The following is a description of a gene set: studied in species Mus musculus Mouse Gene Set: GOBP_MEMBRANE_LIPID_METABOLIC_PROCESS The chemical reactions and pathways involving membrane lipids, any lipid found in or associated with a biological membrane., and this is the list of marker genes: Sftpb, Smpdl3a, Sptlc2 (serine palmitoyltransferase, long chain base subunit 2), Glb1, Neu1, Fut4, Pigo, Lct, Naglu, Th, Elovl5, Pigyl, Serinc1, Elovl1, Pigg, St6galnac3, Htra2, Cers2, Ormdl1, Hacd2, Hacd4, Gla, Gal3st3, Crem, Prkcd, Pigw, St6galnac6, St6galnac5, Vapa, Acer2, Gal3st2, St6galnac1, Pigb, Asah2, B4galt5, Casp7, Pign, Fads3, Pigv, Hacd3, Pigf, Ugt8a, Smpd2, Pigc, St8sia2, Tlcd3b, Sgms2, Dpm3, Degs1, Smpdl3b, Pigt, Gbgt1, St3gal4, Pgap2, Tecr, Eed, Mecr, St6galnac4, Sptssa, Hexa, Sphk1, Gsdmd, Sirt3, Fut2, Pgap3, Dpm2, Arv1, Enpp2, Cers4, Sptlc1 (NCBI Gene Id 97860), Smpd1, Acer3, St8sia4, Fa2h, Ormdl3, Smpd3, Pemt, Etnppl, Zfp750, Smpd5, Pigp, B3galt1, Gal3st1, Cln6, Pgap4, Enpp7, St8sia3, Psap, Sgpp1, Cwh43, Galc, Cln8, St8sia1, Naga, Ccn1, Prf1, Vps54, Kdsr, Abca2, Sptlc3, Elovl4, B4galt4, Pyurf, Pigm, St3gal3, Osbp, Degs1l, Paqr4, Pigu, Cerkl, P2rx7, Cyp1b1, B3galt2, Psapl1, Casp1, Sccpdh, 6430550D23Rik, Agmo, Abca8b, Pgap1, Dpm1, Zpbp2 (zona pellucida binding protein 2), B3gnt5, Alox12b (NCBI Gene Id 11686), B4galt3, B4galnt1, Abca12, Spns2, Asah1, Pla2g15, St8sia5, Samd8, Fut9, Cers1 (ceramide synthase 1), Pnpla1, Gba2, Atg7, Plpp3, A3galt2, Rack1, Itgb8, Pigh, Gpaa1, Sptssb, Cyp4f39, Neu3, Hacd1, Flvcr2, B3galt4, Cers3, St3gal6, Elovl2, Piga, Elovl7, Bax, Pigs, Naaa, Tnfrsf1a, Sgpl1, Pigq (NCBI Gene Id 23889), Cers5, Mppe1, Nsmaf, Elovl3, Pla2g6, Plpp2, Acer1, B4galt6, Mgst2, Map7, Degs2, Tnf, P2rx1, Elovl6, Kit, Neu2, Gba1, Plpp1, Cerk, Gm6993, Gm2a, Pigx, Pigz, Cert1, Gzmb, St3gal1, Tm9sf2, St8sia6, Abca8a, A4galt, Neu4 (sialidase 4), Smpd4, Pigl, Pigk, Sphk2, Sgms1, Cers6 (NCBI Gene Id 99389), Hexb, Ormdl2, Aloxe3, Slc30a5, Ugcg, Agk, Fut7, Cel, Pnliprp2, Sgpp2, St3gal2, Mfsd8